Given this list of marker genes RAB33A, ZNF3, EPS8L3, LANCL1, NOTCH2NLA, KRBA1, PLEKHS1, APOOL, AMMECR1, FNDC3A, TSC1 (TSC complex subunit 1), PLA1A, NCAN, C9orf72, LYN, TTC9, ZNF704, SLC4A8, PARP15, TMPRSS13, RAVER2, ZMYM3 (NCBI Gene Id 9203), GRM5, SH3KBP1, RABGAP1 (RAB GTPase activating protein 1), CDH11, NEK2, PBX2, FRA10AC1, SHISAL1, NALCN, PPIP5K2, CHTF8, SDK1, CEP15, KIF21B, EPM2AIP1, FOXN1, GLYATL3, STYX, CACNA1E (calcium voltage-gated channel subunit alpha1 E), DLC1, MARK1, ERBB3, IPPK, TMEM164, MMD, TIGAR, ADAM23, CHD3 (NCBI Gene Id 1107), ABCC1 (NCBI Gene Id 8133), ZNF326, WDR43, SELENOI (NCBI Gene Id 85465), NSD1, NOVA2, COLGALT2, ZNF84, RND3, CTNNA3, SEMA3G, CLASP2, PKD2, KLF14, GKN2, YWHAZ, MEX3C, ASCC3, RPH3A, TTI2, RIMOC1, ATP8B4, CDK5, GOLPH3, BLTP3A, ZEB2, ZDHHC18, GPRASP3 (NCBI Gene Id 80823), SULT1C4, FKBP5, SMIM12 (small integral membrane protein 12), PPM1L (protein phosphatase, Mg2+/Mn2+ dependent 1L), ZBTB43, LIPA, DPF2, CCDC30, MAT1A, STRADA, GPC6, GUCY1A2, SHPRH, LSM11, BTN3A3, MAPK8, MARVELD3, ASTN1, SLC18A1, OSBP, ATP1B1, TMEFF2, KCMF1, YIPF5, ADPRHL1, KLF8, RAB5B, TACC1, PLCD4, PSTPIP2, MCM10, GEMIN8, ATXN2L, GORASP1, RGS8, USP46, SRRM4, BCL9, ACP7, THSD7A, SNX27, VPS25, SLC7A14, SENP1, TMEM217, GSPT1, TAP2, HOXB3, SPOCK3, CREBL2, LMBRD2, DNAJC6, GSTT2B, LRRC51, WDR26 (NCBI Gene Id 80232), SNRK, ABHD13, RAB8B, HDGFL3, AFF2 (ALF transcription elongation factor 2), EBF3, YWHAG, DLG3, ANKRD17, TRABD2B, TGFBR1, FAXC, ARFGEF2, DGKH, NPAS3, DCAF16, RBM4B, ZDHHC9, RNF175, SH3D19, NEUROD1, PREX2, ZBTB20, BRPF1, PFN2, RTL5, AAK1, PIGN, F5, HLA-DQA1, SPICE1, VTCN1, HSPB6 (heat shock protein family B (small) member 6), CDCA3, TNIK, MEGF8, EFNA5, NCBP3, DSCAM, GAS7, HMGN5, MYCL, CLEC7A, SNX11, MARCHF4, ERGIC1, TESK2, MECP2, NUDC, KSR2, FMO1, MIA3, SAMD10 (NCBI Gene Id 140700), ST3GAL1, STRN4, RPP14, VCL, LZTS3, ZBTB9, HSPA9, KNSTRN, FECH, KPNA3, ARFGEF3, FAM234B, LOX, SUOX, C1orf198, CLASP1, PLS3, KMT2A, ANTXR1, ENTPD4, ZDHHC21, MBOAT7 (membrane bound O-acyltransferase domain containing 7), RICTOR, PAPPA, SHTN1, RAPGEF6, FBXO4, POU3F4, ATP6V1G2, TIGD3, CXCL14, AAMP, ADNP, ACER2, PCDH12, AGO3, VANGL2, here is a description of the gene set: Genes predicted to be targets of miRBase v22 microRNA hsa-miR-3153 in miRDB v6.0 with MirTarget v4 prediction scores > 80 (high confidence targets). Human Gene Set: MIR3153 species: Homo sapiens from publication Chen Y, Wang X (PMID 31504780)